The following is a description of a gene set: studied in species Mus musculus Mouse Gene Set: chr5B2, and this is the list of marker genes: Grk4, 4930478P22Rik, Nicol1, Cpz, Msantd1, 4930557J02Rik, Mir7024, Fam193a, Rgs12, Gm15522 (predicted gene 15522), Poln, Rnf4, Mir7036b (microRNA 7036b), Gm30708, Hmx1, Letm1, Gm19798 (predicted gene, 19798), Mfsd10, Adra2c, Slbp, Nat8l, Haus3, Tnip2, Mir3097, Add1, Tacc3, Sh3bp2, Plk-ps1, Nelfa (negative elongation factor complex member A, Whsc2), G630022F23Rik, Gm25918, Cfap99, Gm10459, E130018O15Rik, 4930442P19Rik, Nop14, Hgfac, Gm5553, Gm22847, Zfyve28, Fgfr3, Gm10059, Dok7, Tmem129, Mxd4, Lrpap1, Nsd2, Htt